The following is a description of a gene set: Human Gene Set: GOCC_PROTEIN_COMPLEX_INVOLVED_IN_CELL_MATRIX_ADHESION studied in species Homo sapiens Any protein complex that is capable of carrying out some part of the process of cell-matrix adhesion., and this is the list of marker genes: TNR, TNN, MMRN2 (NCBI Gene Id 79812), TNC, NID1, TNXB, LAMC1, VTN, LAMB1, LAMA2, LAMA1, MMRN1, PLAU, LAMB2, EMILIN2, EMILIN1 (NCBI Gene Id 25883), PLAUR